The following is a description of a gene set: Tyrosine kinase inhibitors (TKI) of the epidermal growth factor receptor (EGFR) produce objective responses in a minority of patients with advanced-stage non-small cell lung cancer (NSCLC), and about half of all treated patients progress within 6 weeks of instituting therapy. Because the target of these agents is known, it should be possible to develop biological predictors of response, but EGFR protein levels have not been proven useful as a predictor of TKI response in patients and the mechanism of primary resistance is unclear. We used microarray gene expression profiling to uncover a pattern of gene expression associated with sensitivity to EGFR-TKIs by comparing NSCLC cell lines that were either highly sensitive or highly resistant to gefitinib. This sensitivity-associated expression profile was used to predict gefitinib sensitivity in a panel of NSCLC cell lines with known gene expression profiles but unknown gefitinib sensitivity. Gefitinib sensitivity was then determined for members of this test panel, and the microarray-based sensitivity prediction was correct in eight of nine NSCLC cell lines. Gene and protein expression differences were confirmed with a combination of quantitative reverse transcription-PCR, flow cytometry, and immunohistochemistry. This gene expression pattern related to gefitinib sensitivity was independent from sensitivity associated with EGFR mutations. Several genes associated with sensitivity encode proteins involved in HER pathway signaling or pathways that interrelate to the HER signaling pathway. Some of these genes could be targets of pharmacologic interventions to overcome primary resistance. Human Gene Set: COLDREN_GEFITINIB_RESISTANCE_UP from publication Coldren CD, Helfrich BA, Witta SE, Sugita M, Lapadat R, Zeng C, Barón A, Franklin WA, Hirsch FR, Geraci MW, Bunn PA Jr (PMID 16877703) species: Homo sapiens Genes up-regulated in NSCLC (non-small cell lung carcinoma) cell lines resistant to gefitinib compared to the sensitive ones., and this is the list of marker genes: FBXO30, PDHA1, PCGF6, RFK, IKBIP, TRMT1, OLFM1, WDR62, ALDH1B1, KMT2B, TBL1X (NCBI Gene Id 6907), RAD50, BMERB1, DZIP1, SLC39A14, SELENOM, DLX1, QPCT, MDM4, BORCS7, GOT1, GAS5, TWNK, CEBPG, UBA2, ACTR1A, KCTD15, CTPS1, SOX12, RABEPK, UBE2M, CSGALNACT2, TIMM50, ARMH3, SACS, RHOQ, JAM3, KLHL15, ADISSP, SLC7A1, POLRMT, TUB, ALDH1A1, ARL3, PRELID1 (PRELI domain containing 1), TRAF5, COPRS, SUPV3L1, C18orf21, NAP1L1, SLC47A1, NFKBIZ, ZEB1, MAP1B, TAMM41, UCHL1, DPH5, FSD1L, BMS1, LOC102724701, SRRT, MLLT11, ITPRIP, P3H1, TMEM158 (transmembrane protein 158), ID3, NXPE3, NOL8, MFSD12, PPP2R1B, PARVB, TTL, RFLNB, PTPRG, IARS1, USP36, TRNT1, LIX1L, PPIF, NSMAF, CDH2, IDE, COX15, NAA10, CRTAP, CDK5RAP2, PDCD11